Given this list of marker genes HYOU1, SASH3, SEC61A1 (SEC61 translocon subunit alpha 1), CD247, KNSTRN, CASP8 (NCBI Gene Id 841), IKBKG, CD70, AICDA, CTPS1, ARHGEF1, TNFRSF9, BTK, REL, RAC2, ICOS, CARMIL2, MALT1, B2M, CORO1A, IRF2BP2, CD81, CBLB, RNF31, POLD1, TNFRSF13B, TCF3, ALG12, CARD11, TNFRSF13C, CR2, SHARPIN, IRAK4, RIPK1, PIK3CD, CD19, LRBA, here is a description of the gene set: A reduced ability to synthesize postvaccination antibodies against toxoids and polysaccharides in vaccines, as measured by antibody titer determination following vaccination. Human Gene Set: HP_DECREASED_SPECIFIC_ANTIBODY_RESPONSE_TO_VACCINATION studied in species Homo sapiens Decreased specific antibody response to vaccination